Given this list of marker genes Sestd1, Rem1, Ubr3, Fbxo11, Bin1, here is a description of the gene set: Mouse Gene Set: GOBP_NEGATIVE_REGULATION_OF_CALCIUM_ION_TRANSMEMBRANE_TRANSPORT_VIA_HIGH_VOLTAGE_GATED_CALCIUM_CHANNEL Any process that stops, prevents or reduces the frequency, rate or extent of calcium ion transmembrane transport via high voltage-gated calcium channel. species: Mus musculus